The following is a description of a gene set: Human Gene Set: GOBP_FOLLICLE_STIMULATING_HORMONE_SECRETION species: Homo sapiens The regulated release of follicle-stimulating hormone, a gonadotropic glycoprotein hormone secreted by the anterior pituitary., and this is the list of marker genes: CGA, INHBA, FOXL2, SMAD4, LEP, INHA, INHBB, TBX3